Given this list of marker genes SCRN1, RAPGEF4, C9orf72, PSEN1, CASP3, BSN, DNAJC5, LPAR1, PRKAR1B, PPP3R1, PLD1, RAB3B, ARHGDIA, PLS3, SYN1, here is a description of the gene set: Any process that modulates the frequency, rate or extent of the synaptic vesicle cycle. species: Homo sapiens Human Gene Set: GOBP_REGULATION_OF_SYNAPTIC_VESICLE_CYCLE